The following is a description of a gene set: studied in species Homo sapiens Simplified gyral pattern An abnormality of the cerebral cortex with fewer gyri but with normal cortical thickness. This pattern is usually often associated with congenital microcephaly. Human Gene Set: HP_SIMPLIFIED_GYRAL_PATTERN, and this is the list of marker genes: RNU12, PRKDC, CUL4B, LMNB1, TSEN2, PNKP, LRPPRC, YRDC, STAMBP, CEP295, KIF14, DYNC1I2, NSRP1, LIPT2, MPDZ, XRCC4, CDK6, ARID2, INTS11, OSGEP, CASK, ASPM (NCBI Gene Id 93990), ZNF335, CEP152, SMARCB1, NDUFA6, C2CD3, EXOC7, SOX4, NDE1, ERCC1, POGZ, CIT, CSNK2A1, PSAT1, SMARCA4, TMEM222, VLDLR, LMNB2, STIL, IER3IP1, CLP1, CENPE, KIF11, CDC40, CDK5RAP2, TTC5, TRAIP, WWOX, GFM2, PDCD6IP, TUBB3, SMARCC2, ASNS, COPB2, KATNB1, TUBGCP6, ZNF526, ANKLE2, ARID1A, DCHS1, VRK1, PPIL1, RTTN, WDR62, QARS1, SMARCE1, ARID1B, AHDC1, SON, SOX11 (SRY-box transcription factor 11), DPF2, MAST1, SMARCD1, PLK4, SMPD4, FOXG1, DONSON, SPOP, GMNN, FKRP, GLS, TRAPPC12, MED27, TUBB2A